Given this list of marker genes Jun (jun proto-oncogene), Hspa1b, Rgs1 (regulator of G-protein signaling 1), Jund, Hspa1a, Dusp1, Fosb, Fos, here is a description of the gene set: studied in species Mus musculus Genes negatively differentially expressed in cell type: MigDC (migratory dendritic cell) upon treatment with cytokine: APRIL in mouse lymph nodes in vivo. Cytokines mediate cell-cell communication in the immune system and represent important therapeutic targets. A myriad of studies have highlighted their central role in immune function, yet we lack a global view of the cellular responses of each immune cell type to each cytokine. To address this gap, the authors created the Immune Dictionary, a compendium of single-cell transcriptomic profiles of more than 17 immune cell types in response to each of 86 cytokines (>1,400 cytokine-cell type combinations) in mouse lymph nodes in vivo. A cytokine-centric view of the dictionary revealed that most cytokines induce highly cell-type-specific responses. For example, the inflammatory cytokine interleukin-1β induces distinct gene programmes in almost every cell type. A cell-type-centric view of the dictionary identified more than 66 cytokine-driven cellular polarization states across immune cell types, including previously uncharacterized states such as an interleukin-18-induced polyfunctional natural killer cell state. from publication Cui A, Huang T, Li S, Ma A, Pérez JL, Sander C, Keskin DB, Wu CJ, Fraenkel E, Hacohen N (PMID 38057668) Mouse Gene Set: CUI_MIGDC_APRIL_RESPONSE_DN